Given this list of marker genes MMP1, IL6, KLF6, MADCAM1, PTPN14, RYBP, NCOA3, PRKCD, IGHV5-78, MAP3K1, EIF2AK2, TGFB1, ACP2, PRKCI, IGKC, PMAIP1, here is a description of the gene set: studied in species Homo sapiens from publication Wu CG, Salvay DM, Forgues M, Valerie K, Farnsworth J, Markin RS, Wang XW (PMID 11439330) Human Gene Set: WU_HBX_TARGETS_2_DN Hepatitis B virus (HBV) is a major risk factor for the development of hepatocellular carcinoma (HCC). HBV encodes the potentially oncogenic HBx protein, which mainly functions as a transcriptional co-activator involving in multiple gene deregulations. However, mechanisms underlying HBx-mediated oncogenicity remain unclear. To determine the role(s) of HBx in the early genesis of HCC, we utilized the NCI Oncochip microarray that contains 2208 human cDNA clones to examine the gene expression profiles in either freshly isolated normal primary adult human hepatocytes (Hhep) or an HCC cell line (SK-Hep-1) ecotopically expressing HBx via an adenoviral system. The gene expression profiles also were determined in liver samples from HBV-infected chronic active hepatitis patients when compared with normal liver samples. The microarray results were validated through Northern blot analysis of the expression of selected genes. Using reciprocally labeling hybridizations, scatterplot analysis of gene expression ratios in human primary hepatocytes expressing HBx demonstrates that microarrays are highly reproducible. The comparison of gene expression profiles between HBx-expressing primary hepatocytes and HBV-infected liver samples shows a consistent alteration of many cellular genes including a subset of oncogenes (such as c-myc and c-myb) and tumor suppressor genes (such as APC, p53, WAF1 and WT1). Furthermore, clustering algorithm analysis showed distinctive gene expression profiles in Hhep and SK-Hep-1 cells. Our findings are consistent with the hypothesis that the deregulation of cellular genes by oncogenic HBx may be an early event that favors hepatocyte proliferation during liver carcinogenesis. Genes down-regulated by expression of HBV X protein (HBVgp3) in primary hepatocytes.